Given this list of marker genes Afap1l2, Fam83b, Dab2ip, Errfi1, Ralb, Socs5, Nup62, Ptprj, Cadm1, Psen2, Agr2, Snx5, Tgfb1, Cbl, Socs4, Esr1, Lgmn, Rnf126, Fer, Dusp3 (dual specificity phosphatase 3 (vaccinia virus phosphatase VH1-related)), Hip1r, Ceacam1, Nppa, Adra2a, Ptprf, Tfap2a, Tsg101, Gper1, Egf, Rtn4, Rbpj (recombination signal binding protein for immunoglobulin kappa J region), Pde6g, Dgkd, Pde6h, Acp4, Rab7, Zfyve28, Plaur, Sh3tc2, Hip1, Wdr54, Agt, Zgpat, Rala, Chmp6, Cblb, Mvb12b, Rhbdf2, Cnot9, Vps25, Grb2, Mmp9, Neu3, Spry2, Esr2, Psen1, Rnf115 (NCBI Gene Id 99831), Cblc, Ptpn12, Ceacam2, Gprc5a, Egfr, Itga1, Hap1, Ptpn2, Shkbp1, Sos1, Rhbdf1, Ccdc88a, Adam17 (NCBI Gene Id 236174), Mvp, Cdh13, Fasl, Mvb12a, here is a description of the gene set: Any process that modulates the frequency, rate or extent of ERBB signaling pathway. Mouse Gene Set: GOBP_REGULATION_OF_ERBB_SIGNALING_PATHWAY studied in species Mus musculus